The following is a description of a gene set: Mouse Gene Set: GOBP_POSITIVE_REGULATION_OF_ENDOTHELIAL_CELL_CHEMOTAXIS studied in species Mus musculus Any process that activates or increases the frequency, rate or extent of endothelial cell chemotaxis., and this is the list of marker genes: Vegfa, Tmsb4x, Hspb1, Sema5a, Fgfr1, Fgf16, Prkd2, Smoc2, Fgf2 (fibroblast growth factor 2), Lgmn, Snai2, Prkd1, Kdr, Met, Shh, P2rx4, Fgf18